The following is a description of a gene set: species: Homo sapiens Human Gene Set: GSE23695_CD57_POS_VS_NEG_NK_CELL_UP Thirty to 60% of CD56dimCD16bright NK cells in healthy adults express CD57, which is not expressed on immature CD56bright NK cells or fetal and newborn NK cells. We hypothesized that CD57+ NK cells within the CD56dim mature NK cell subset are highly mature and might be terminally differentiated. We used microarrays to assess the transcriptional differences between CD57+ and CD57neg NK cells within the CD56dim mature NK subset. from publication Lopez-Vergès S, Milush JM, Pandey S, York VA, Arakawa-Hoyt J, Pircher H, Norris PJ, Nixon DF, Lanier LL (PMID 20733159) Genes up-regulated in NK cells: B3GAT1+ versus B3GAT1-., and this is the list of marker genes: URI1, AP1M1, RREB1, GRAMD1A, GADD45GIP1, ZNF652, LSM12, MTRES1, RASA3, EBAG9, ZNF878, HEBP1, EPS15, CEP41, KIF2A, ALDH3A2, RNF145, MADD, SRP72, NDUFAF4, POLR1B, SPN, BBS5, PABIR1, RANBP2, TAF6, OPA3, SYNRG, PRRC1, RPF2, MEAK7, MRPS12, GPATCH2L, METTL8, MGAT2, HERC4, RCC1L, CTU1, SAMSN1, ST6GALNAC4, MYCBP2, SHTN1 (NCBI Gene Id 57698), CDCA2, TSFM, INPP5E, STRN3, PXN, RBPJ, DMTF1, ANKHD1, PARP8, ZNF823, TSEN15 (tRNA splicing endonuclease subunit 15), ATP23, ZC3HAV1L, BEND3 (NCBI Gene Id 57673), PPP2CA, CISD2 (NCBI Gene Id 56831), SEC24B, DOLK, ZNF862, DNAJC2, CHD1L, PYCR3, BTLA, TUBA8, PNPO, TRAPPC2B, LFNG, MKI67, SDHAF4, ZMYM4 (NCBI Gene Id 9202), ZBTB45, ARHGAP30, ZNF639, POLR2M, PARPBP, CSF1, TRMT11, RGS19, MED7, CYP1B1, ELP3, LTB, PPIL2, CTBP1, PUF60, TUBB (NCBI Gene Id 95295), ANKRD27, PELP1, FAM107B, MRPL22, EPS15L1 (epidermal growth factor receptor pathway substrate 15 like 1), ANKRD46, DUSP6, TMEM119, PARN, EIF4G3, SLC37A3, FASTKD5, CTCF, DUS1L, BMF, PTPRE, NTMT1, HDAC2, SMYD5, SPC25, SERBP1, PBRM1, TYSND1, DYNLT1, PSMC5, GRAMD4, PIP5K1C, BTBD6, DCTN5, FAM3C (FAM3 metabolism regulating signaling molecule C, NCBI Gene Id 10447), TRIM32 (NCBI Gene Id 3971), MRPS18B, HHEX, RCBTB2, PTGES2, BAG2, PHF20, ZNRD2, CYB561D1, PTGIR, RERE, APEH, ZNF282, WDR12, ZNF280D, CANT1, ADAM8, PFAS, PFKFB3 (6-phosphofructo-2-kinase/fructose-2,6-biphosphatase 3), DNLZ, DIPK1A, CENPB, CD81, ARHGAP31, WDR11, INF2 (inverted formin 2), FAM111A, BRD7, SH3PXD2B, CDC7, NSD1, TXLNA, PLXNA1, CDPF1 (NCBI Gene Id 150383), POLR3H, ENC1, TELO2, AKAP1, THEMIS2, ZRANB2, RPP25L, SLC29A3, ST8SIA1, CERK, SLC12A9, MFSD5, YEATS4, CEBPA, HEATR3, MTX1, SRXN1, AQR, ZFP91, CDK5RAP1, FRRS1, DLST, LMNB2, NOP16 (NCBI Gene Id 51641), MRPS23, RNF7, MBD1, SLC9A6, FGD2, ATG16L2, MRPL40, OTUD4, NIBAN2, PWP2, PIK3CG, TUBB6, LLGL1, NABP1, PSMG2, ZFYVE19, FFAR4, SERPINB9, HNRNPUL2, UQCC3, B3GALT6, GAR1, QSOX2